Given this list of marker genes SPEN, ADNP, PRKACA, FGFR1, CDKN2A, NDST1, ANK3, PHF21A, WT1, CDH23, KCNJ11, SH2B1, SDCCAG8, CFH, DLK1, AKT2, RNF135, NPHP1, RAI1 (NCBI Gene Id 6600), TCF20, USP48, MTMR14, UCP2, MOG, SLC7A7, CFAP410, GNAS-AS1, MEF2A, HCRT, ARL13B, WDPCP, PCNT, CARTPT, TBL2, IGFALS, RIT1, ASH1L, P4HTM, XYLT1, PAX4, STX16, HSD11B1, RPS6KA3, HNF1A, MTFMT, PAX6, FIBP, EIF4H, MYT1L, CYP7A1, UBE4B, SLC9A7, KCNJ18, EXOC6B, ABCB4, CASZ1, TP53, AP4M1, TAF1, MAPK8IP3, SPIN4, SOS1, TMEM43, NEUROD1, TMEM67, SCAPER, BBIP1, PIGA, SMARCB1, SUPT16H, POMC, GHR, INS, APOE, GTF2IRD2, PRMT7, MLXIPL, TBX3, NHLH2, MCM3AP, EHMT1, TRHR (thyrotropin releasing hormone receptor), NIN, CLIP2, THRA, SNORD116-1, DYNC2I2, KMT2C, DEAF1, IER3IP1, FBXO11, SKI (NCBI Gene Id 6497), BBS2, FEZF1, BAZ1B, PTEN, HECTD4, CEP290, MYF6, RERE, ATRX, PROKR2, SUFU, SNORD115-1, CTNNB1, PTCH1 (NCBI Gene Id 8015), PHKB, UNC45B (unc-45 myosin chaperone B), JMJD1C, HELLPAR, CHD8, TOGARAM1, HDAC8, EP300, HSPG2, WAC, SPRY4, PHKA2, DNMT3A, SOX2, CCDC141, WNT4, UBE3C, ERMARD, POU1F1, BIN1, GP1BB, HIRA, TTC8, APPL1, MIA3, CANT1, SPTBN1, DCC, NDN, TMEM218, ALB, ATP7B, METTL27, SYNE2, BLK, FGF8, H6PD, ODC1, DYRK1B (NCBI Gene Id 9149), AFF4, MAGEL2, WDR11, ENPP1, AP4S1, COL10A1, CELA2A, PRKAR1B, LZTFL1, PDGFB, ARVCF, SMC3, IFT27, PSMD12, ATP6AP2, IFT172, SMO, ALMS1, MMP23B, SETD1A (SET domain containing 1A, histone lysine methyltransferase), BBS4, ZNRF3, SOX10, OTX2, ZPR1, FOXP1, RYR1, PNPLA6, TACR3, PROP1, SCAF4, LHX4, PDSS1, SPG11, HDAC4, OCA2, FKBP6, ELN, PIGT, FMR1 (fragile X messenger ribonucleoprotein 1), ADCY3, PKDCC, GABRD, PDX1, FHL1 (NCBI Gene Id 2273), GTF2IRD1, NR3C1, TRAF3IP1 (NCBI Gene Id 26146), FGF17, SRRM2, GNAI1, PROK2, GJA5, INPP5E, AP1S3, POGZ, NIPBL, CFAP418, LHX3, CTSK, SCLT1, BPTF, FGD1, CNTNAP2, VPS13B, CACNA1S, CPE, TFE3, PNKP, ADRB3, OFD1, LEP (NCBI Gene Id 3952), BRAF, HLA-DQB1, BDNF, CD46, ARNT2, COPB1, GCK, GNAS, MKRN3, DNM2, BBS7, SDC3, BBS1, SHOC2, HERC1, PRDM16 (NCBI Gene Id 647868), CEP19, PIK3CA, RBMX, EMD, BBS12, NKAP, RREB1, SETBP1, CNNM2, RAP1B, AP4E1, CYP19A1, MECP2, ZBTB7A, BAP1, IL36RN, SRY, GATA4, YY1, LUZP1, SATB1, HS6ST1, ACADVL, IGSF1, PWRN1, MKKS, THRB, TRIP4, SMARCE1, THOC2, LARS2, KIDINS220, DICER1, ARL6, TAF6, UCP3, NDNF, DDX6, NCF1 (neutrophil cytosolic factor 1), VPS37D, POU3F4, CEL, PRKCZ, XRCC4, IGF1R, TAOK1, TNFSF4, TMCO1, HLA-DRB1, CEP164, UBE2A, UBE3A, ZBTB20 (zinc finger and BTB domain containing 20), ARMC5, CREBBP, SETD2, PHLDB1, SLC25A4, PHIP, PPARG, BBS9, LEPR, ACBD6, RAD21, PIGL, EIF2S3 (eukaryotic translation initiation factor 2 subunit gamma), TMEM270, RTL1, BUD23, CTSH, NSD1, ABHD5, COMT, SIN3A, DUSP6, DDB1, KDM1A, MKS1, BLM, MTOR, LMNA, SHOX, PWAR1, TRAF7, CHD7, MC4R, DPYD, MEGF8, TERT, KLF11, AP4B1 (NCBI Gene Id 10717), UFD1, HEATR3, NR0B2, ADGRL1, LIMK1, PDPN, SYNE1, BBS10, LAS1L, NF2, CCDC28B, PDE11A, GTF2I, STEEP1, TUB, GHRL, SEC24C, ABCC9, GJA8, FGFR3, PRORP, PCSK1, EDNRB, PHKG2, HERC2, PNPLA2, DMPK, PGM2L1, SNRPN (NCBI Gene Id 6638), COA3, ZNF365, SEMA3A, KDM6A, MAN1B1, RAB23, SOX3, CFI, RNPC3, P2RY11, PRKAR1A, TRIM32, AIP, CUL4B, DNAJC30, TBC1D2B, LIPE, ANOS1, IGF1, STX1A, BRD4, ABCC8, USP7, ZFX, IFT74, IQSEC2, SH3KBP1, MEG3, SMC1A, SECISBP2, PIGN, TRIP12, KMT2D, GLI3, RFC2, USP8, SLC10A7, IL17RD, TBX1, PHF6, HNF4A, SMAD4, PDE4D, BBS5, AKT1, GABRA3, ZNF711, HESX1, FLRT3, NPAP1, DIS3L2, TMLHE, MEN1, KCNAB2, AGRP, NTRK2, FXR1, FLII, ATP10A, RAF1, TRAPPC9, HACE1, SIM1, here is a description of the gene set: Increased body weight Abnormally increased body weight. Human Gene Set: HP_INCREASED_BODY_WEIGHT studied in species Homo sapiens